Given this list of marker genes IKBKE, TRADD, TNF (NCBI Gene Id 7124), OPTN (NCBI Gene Id 337928), RIPK1 (receptor interacting serine/threonine kinase 1), FADD, SPATA2, BIRC2, OTUD1, SHARPIN, BIRC3, RBCK1, TNFRSF1A, CYLD, TBK1, USP2, MIB2, TRAF2 (TNF receptor associated factor 2), CASP8, OTUD7B, USP21, RNF31, XIAP, TNFAIP3, USP4, here is a description of the gene set: Human Gene Set: REACTOME_TNFR1_INDUCED_PROAPOPTOTIC_SIGNALING TNFR1-induced proapoptotic signaling species: Homo sapiens